The following is a description of a gene set: Small ligand GPCRs studied in species Homo sapiens Human Gene Set: WP_SMALL_LIGAND_GPCRS, and this is the list of marker genes: MTNR1B, CNR1, PTAFR, PTGDR, PTGER4, PTGER1, PTGIR, PTGER3, S1PR1 (sphingosine-1-phosphate receptor 1), CNR2, GPR50, S1PR2, PTGFR, TBXA2R, S1PR4, PTGER2, S1PR3, LPAR1, MTNR1A